Given this list of marker genes ADIPOQ, EFHB, GMNN, CLN5, PIN1, DAZAP2, HMGA2, GATA3, ADD1, ITGB1BP1, E2F1, EIF3E, SKI, SOX11, ADD2, SUMO4, SUMO3, CSNK2B, ADAM15, MITD1, NCBP1, PARP9, NES, RB1, IFIT1, GOLGA2, FLOT1, EIF4G1, EPHA4, BMP4, DOT1L, CTNNBIP1, USP33, MED25, IGF1, NME1, CEBPG, MAPK8, GNL3L, XIRP1, PSEN1, SUMO1, IFNG, MMP9, HMGB1, BDNF, GZMA, SLPI, ILRUN, BCL3, NFIB, GEMIN2, FOXC1, POU4F2, GSK3B, GREM2, RACK1, BTBD1, HJURP, JUN, TERT, H1-0, DDX11, PINX1, NVL, HAND2, IDE, GTF2F1, MET, POU4F1, RARA, PLN, DPH3, DTX3L, AKTIP, LDLRAP1, TIAM1, ROCK1, TLE5, LRPAP1, EIF3C, PLAUR, RALB, STYX, RSF1, ITGA4, BTAF1, STMN1, CARD16, KDM4D, RIPOR2, MDFI, RAPGEF2, LEF1, RPL11, PSME3IP1, NMD3, CFHR5, TWIST1, NEUROD1, ZNF593, TFAP4, TRIM21 (tripartite motif containing 21), EPB41, ABL1, CARD18, EDF1, HES1, CAMK1, RAN, GPSM1, BAX, DACT1, GAS8, AURKA, PEX14, CFHR1, NIBAN2, BAMBI, IFIT2, ZC4H2, MIA2, IFI16, PYHIN1, TNKS, MIR148A, CFHR2, DNAJB2, SIRT2 (NCBI Gene Id 22933), USP9X, TXN, EGF, RNF220, WAPL, MIR27B, TMC8, PEX19, NSD1, CSNK1E, SYMPK, IL10, ZBTB7A, GATA1, PTPRF, HEY2, CPNE1, SMO, TRIM6, GTF2B, CDT1, RIPOR1, here is a description of the gene set: studied in species Homo sapiens Any process that modulates the frequency, rate or extent of binding, the selective interaction of a molecule with one or more specific sites on another molecule. Human Gene Set: GOBP_REGULATION_OF_BINDING